The following is a description of a gene set: Catalysis of the transfer of a methyl group from a donor to a nucleoside residue in an RNA molecule. studied in species Mus musculus Mouse Gene Set: GOMF_RNA_METHYLTRANSFERASE_ACTIVITY, and this is the list of marker genes: Tarbp1, Fbll1, Mrm3, Henmt1, Trmt10a, Cmtr2, Bud23, Mettl15, Lcmt2, Tgs1, Thumpd3, Mettl6, Fbl (NCBI Gene Id 14113), Trmt5, Mettl14, Nsun6, Fdxacb1, Trmt2b, Mettl2, Tfb1m, Trmt2a, Thumpd2, Trmt61a, Bcdin3d, Alkbh8, Trmt10b, Tfb2m, Zcchc4, Mepce, Trmt13, Mettl5, Trmt10c, Trmo, Tmt1a2, Trmt11, Mettl16, Rnmt, Tmt1a3, Trmt1l, Tyw3, Mettl8, Nsun5, Nsun3, Pcif1, Nsun4, Dimt1, Trdmt1, Mettl3, Ftsj3, Mettl4, Ftsj1, Cmtr1, Emg1, Trmt9b, Trmt44, Nsun2 (NCBI Gene Id 28114), Trmt12, Mrm1 (mitochondrial rRNA methyltransferase 1), Mettl1, Nop2, Tmt1a, Trmt1, Mrm2